Given this list of marker genes FAS, TNFRSF10D, TP53I3, TNFRSF10A, AIFM2, TP73, TRIAP1, BAX, CHM, CRADD, TMEM219, TP53BP2, RABGGTA, PIDD1, CASP10, PMAIP1, NLRC4, TNFRSF10C, CASP6, PRELID3A, BID, PPP1R13B, TP53, CASP1, TP53AIP1, CASP2, BCL6, TP53INP1, TP63, RABGGTB, BIRC5, BCL2L14, CREBBP, TNFRSF10B, PRELID1, ATM, PERP, STEAP3, APAF1, ZNF420, NDRG1, BNIP3L, IGFBP3, BBC3, here is a description of the gene set: species: Homo sapiens TP53 Regulates Transcription of Cell Death Genes Human Gene Set: REACTOME_TP53_REGULATES_TRANSCRIPTION_OF_CELL_DEATH_GENES